The following is a description of a gene set: Human Gene Set: IM_SREBF1A_TARGETS from publication Im SS, Hammond LE, Yousef L, Nugas-Selby C, Shin DJ, Seo YK, Fong LG, Young SG, Osborne TF (PMID 19564420) Genes differentially expressed in liver tissue upon knockout of the 1a isoform of SREBF1. We generated a line of mice in which sterol regulatory element binding protein 1a (SREBP-1a) was specifically inactivated by insertional mutagenesis. Homozygous mutant mice were completely viable despite expressing SREBP-1a mRNA below 5% of normal, and there were minimal effects on expression of either SREBP-1c or -2. Microarray expression studies in liver, where SREBP-1a mRNA is 1/10 the level of the highly similar SREBP-1c, demonstrated that only a few genes were affected. The only downregulated genes directly linked to lipid metabolism were Srebf1 (which encodes SREBP-1) and Acacb (which encodes acetyl coenzyme A carboxylase 2, a critical regulator of fatty acyl-CoA partitioning between cytosol and mitochondria). ACC2 regulation is particularly important during food restriction. Similar to Acacb knockout mice, SREBP-1a-deficient mice have lower hepatic triglycerides and higher serum ketones during fasting than wild-type mice. SREBP-1a and -1c have identical DNA binding and dimerization domains; thus, the failure of the more abundant SREBP-1c to substitute for activating hepatic ACC2 must relate to more efficient recruitment of transcriptional coactivators to the more potent SREBP-1a activation domain. Our chromatin immunoprecipitation results support this hypothesis. species: Mus musculus, and this is the list of marker genes: ACACB, SREBF1, ATOX1, ULK2, DPY19L3